The following is a description of a gene set: Human Gene Set: GAVISH_3CA_METAPROGRAM_ENDOTHELIAL_INTERFERON In this study, an extensive analysis was conducted to define meta-programs (MPs) capturing intra-tumor heterogeneity across a spectrum of tumor types. The approach utilized non-negative matrix factorization (NMF) to analyze each cell type separately within individual tumor samples. This involved the analysis of malignant cells, macrophages, fibroblasts, endothelial cells, epithelial cells, T-cells, and B-cells. NMF was executed with varying parameter values (K=4, 5, 6, 7, 8, 9), thereby generating 39 programs for each cell type per sample. Each NMF program was summarized by the top genes based on NMF coefficients.\nRobust MPs were then delineated for each cell type using a set of stringent criteria, including recurrence within the same tumor, similarity to programs in other tumors, and non-redundancy within a tumor. Subsequently, these robust NMF programs were clustered (per cell type) based on Jaccard similarity, leading to the identification of MPs associated with each cell type.\nTo enhance the quality of the MPs, a refinement steps were undertaken, involving the removal of MPs suspected of reflecting low-quality data (with an overrepresentation of ribosomal proteins or mitochondrial-encoded genes), single-study inclusion, or similarity to miss-annotated cell types. from publication Gavish A, Tyler M, Greenwald AC, Hoefflin R, Simkin D, Tschernichovsky R, Galili Darnell N, Somech E, Barbolin C, Antman T, Kovarsky D, Barrett T, Gonzalez Castro LN, Halder D, Chanoch-Myers R, Laffy J, Mints M, Wider A, Tal R, Spitzer A, Hara T, Raitses-Gurevich M, Stossel C, Golan T, Tirosh A, Suvà ML, Puram SV, Tirosh I (PMID 37258682) Genes upregulated in subsets of cells of a given type within various tumors species: Homo sapiens, and this is the list of marker genes: PPM1K, EIF2AK2, OAS2, HAPLN3, CMPK2, STAT1, XAF1, IRF7 (interferon regulatory factor 7), GBP4, NT5C3A, TRIM22, MX1, GBP1, EPSTI1, IFI35, UBE2L6, SAMHD1, PARP14, OAS3, RIGI, SAMD9L, SAMD9, CXCL11, APOL6, OAS1, MT2A, IFIT1, GBP2, LY6E, RSAD2, ISG15, IFIT3, PLAAT4, IFI6, SERPING1, IFIT2, WARS1, APOL2 (NCBI Gene Id 23780), MX2, BST2, IFI44, TAP2, IRF1, CXCL10, IFI44L, TAP1, ISG20, LAP3, USP18, TNFSF10